The following is a description of a gene set: Mouse Gene Set: CUI_T_CELL_GD_IL17E_RESPONSE_UP Cytokines mediate cell-cell communication in the immune system and represent important therapeutic targets. A myriad of studies have highlighted their central role in immune function, yet we lack a global view of the cellular responses of each immune cell type to each cytokine. To address this gap, the authors created the Immune Dictionary, a compendium of single-cell transcriptomic profiles of more than 17 immune cell types in response to each of 86 cytokines (>1,400 cytokine-cell type combinations) in mouse lymph nodes in vivo. A cytokine-centric view of the dictionary revealed that most cytokines induce highly cell-type-specific responses. For example, the inflammatory cytokine interleukin-1β induces distinct gene programmes in almost every cell type. A cell-type-centric view of the dictionary identified more than 66 cytokine-driven cellular polarization states across immune cell types, including previously uncharacterized states such as an interleukin-18-induced polyfunctional natural killer cell state. from publication Cui A, Huang T, Li S, Ma A, Pérez JL, Sander C, Keskin DB, Wu CJ, Fraenkel E, Hacohen N (PMID 38057668) Genes positively differentially expressed in cell type: γδ T cell upon treatment with cytokine: IL-17E in mouse lymph nodes in vivo. studied in species Mus musculus, and this is the list of marker genes: Hsp90b1, Adam8, Sdf2l1, Cd82, Ndufaf4, Ostc, Batf, Ppp1r14b, Imp3, Mrpl12, Atp5mk, Fkbp2, C1qbp, Ppa1, Pa2g4, Cd52, Ddx56, Pou2f2, Mettl1, Rars1, Srsf2, Odc1, Nedd4, Serpina3g, Manf, Ly6a, Ybx1, Pdia3, Dkc1, Eif5a, Ly6e, Cyba, Rilpl2, Psme2, Tmsb10, Mrps28, Mif (macrophage migration inhibitory factor (glycosylation-inhibiting factor)), Irak3, Tbl1x, Timm8a1, Tpd52l2, Bst2, Calr, Bax, Prdx1, Erap1, Tmem154, Fam162a, Rpn1, Hnrnpa3, Cxcr6, Pak1ip1, Il27ra, Psme1